Given this list of marker genes PPP4R3A, VRK3, CALM1, SLC39A10, HSP90AB1, PPP4R3B, TIPRL, B3GAT3, PPP4R3C, IGFBP3, CALM3, PPP2R5E, PPP2R5B, PPP1R15A, PPP2R5D, PPP2R5A, CALM2, CD33, PHACTR4, GNA12, VCAN, PPP2R5C, AMBRA1, PTPA, here is a description of the gene set: Binds to and increases the activity of a protein phosphatase. Human Gene Set: GOMF_PROTEIN_PHOSPHATASE_ACTIVATOR_ACTIVITY studied in species Homo sapiens